Given this list of marker genes Hs2st1, Cited2, Zic2, Sfrp1, Prickle1, Tgif1, Bcl10 (B cell leukemia/lymphoma 10), Kdm2b, Rgma, Prkaca, Lhx2, Fuz, Cfl1, Nup50, Ift122, Bmp7, Pfn1, Traf6, Cdk20, Wnt6, Cep290 (centrosomal protein 290), Bmp4, Adm, Gata3, Enah, Sox8, Tctn1, Arhgap35, Prkacb, Ift52, Nckap1, Ift57, Kif20b (NCBI Gene Id 286943), Wdr83, Slc39a12, Nfib, Mthfd1l, Brd2, Tcap, Setd2 (NCBI Gene Id 70927), Tgm2, Stil, Dab2ip, Ctnnb1, Fgf10, Rock2, Irx2, Lias, Vegfa, Bcl2l11, Fgf2, Grem1, Map3k7, Kat2a, Rara, Shank3, Lrp2, Tsc2, Gdnf, Mthfd1, Alx1, Smarca1, Abl1, Zic5, Sall4, Mib1, Sfrp2, Brpf1 (bromodomain and PHD finger containing, 1), Ski, Arid1a, Stk4, Pax2, Mthfr, Eda (ectodysplasin-A), Shh, Cthrc1, Ipmk, Hand1, Vangl2, Tfap2a, Fgf3, Stk3, Sdccag8, Six4, Gatad2a, Fzd6, Ptk7, Abl2, Ywhaz, Hnf1b, Wnt5a, Hectd1, Coq7, Grhl2, Lmo4, Edar, Rab23, Tulp3, Podxl, Pik3cd, Wnt9b, Mir216a, Itgb1bp1, Hesx1, Celsr1, Scrib, Nog, Sema4c, Twist1, Tsc1, Pax8, Six1, Sox9, Nodal, Vasp, Luzp1, Irx3, Tgfb2 (transforming growth factor, beta 2), Tgfb1, T, Kdm2a, Fgf8, Casp3, Rala, Fzd3, Rps7, Spint2, Bbs4, Pax3, Plxnb2, Mks1, Opa1, Dlc1, Folr1, Egf, Mmrn2, Gdf7, Cobl, Spint1, Grhl3 (NCBI Gene Id 230824), Mir126b, Dvl2, Deaf1, Sall1, Notch1, Specc1l, Sdc4, Trim71, Ret, Cluap1, Bmp5, Wnt4, Med12, Atoh8, Phactr4, Ptch1, Cc2d2a, Fgfr2, Sufu, Zeb2, Osr1, Hif1a, Tead2, Tmed2, Apaf1, Sec24b, Mir217, Mir216b, St14, Hoxa1, Ovol2, Rarg, Cecr2, Hes5 (hes family bHLH transcription factor 5), Cdh1, Irx1 (NCBI Gene Id 16371), Casp8, Lrp6 (NCBI Gene Id 77387), Ift172, Glmn, Shroom3 (NCBI Gene Id 52200), Kdm6a, here is a description of the gene set: species: Mus musculus Creation of the central hole of a tube in an anatomical structure through which gases and/or liquids flow. Mouse Gene Set: GOBP_TUBE_FORMATION